Given this list of marker genes PRKAR1B, LRRK2, SCT, CRH, LPAR1, MIF, RAMP3, SESN2, PDE4A (NCBI Gene Id 5141), PKIA, CALCR, PRKACA, ATF1, PRKAR2B, SPATC1L, IAPP, ADIPOQ, PDE3A, EDN1, UCN, PRKAR2A, NPY2R, SCN11A, SFN, APP, PRKAR1A (protein kinase cAMP-dependent type I regulatory subunit alpha), CREB1, MC1R, EDNRA, ADRB2, ADCYAP1R1, GHRHR, AKAP6, PDE10A, here is a description of the gene set: Human Gene Set: GOBP_CAMP_PKA_SIGNAL_TRANSDUCTION studied in species Homo sapiens An intracellular signaling cassette that starts with production of cyclic AMP (cAMP) by adenylate cyclase (either transmembrane or soluble), which activates protein kinase A, and ends with activation of downstream effectors such as the transcription factor CREB that further transmit the signal within the cell.